The following is a description of a gene set: Reactome Pathway: Signaling by LTK in cancer part of: Diseases of signal transduction by growth factor receptors and second messengers studied in species Homo sapiens LTK is a member of the anaplastic lymphoma kinase (ALK)/LTK subfamily within the insulin receptor superfamily of RTKs. LTK encodes an 864-amino-acid protein consisting of extracellular, transmembrane, and tyrosine kinase domains and a short carboxy terminus. The LTK kinase domain shares 80% identity with ALK. The biological role of LTK is not well defined under normal physiological conditions, and unlike ALK, a clear role for LTK in cancer is also not yet well established. LTK is overexpressed in leukemia, and high expression of LTK in early-stage non-small cell lung cancer (NSCLC) has been associated with greater risk of metastasis. More recently, a novel CLIP1-LTK fusion protein has been identified in a small proportion of NSCLC cases., and this is the list of marker genes: PIK3CA, CLIP1, PIK3CB, PIK3R1, MAPK3, MAPK1, PIK3R2